The following is a description of a gene set: species: Homo sapiens Any process that modulates the frequency, rate, extent or accuracy of translational elongation. Human Gene Set: GOBP_REGULATION_OF_TRANSLATIONAL_ELONGATION, and this is the list of marker genes: EIF5AL1, EIF5A, METTL18, ALKBH1, SMYD5, AARS1, EIF4A3, EIF5A2, SHFL, CPEB3, CPEB2, RACK1, SRP9, USP16